Given this list of marker genes Gm10723, Gm22009, Gm37035, 4931440P22Rik, Gm34240, Shox2, Gm9701, 9330121J05Rik, Vmn2r-ps4 (NCBI Gene Id 100124547), Arhgef26, Rpl32-ps, Gm18588, Gm17952, Kpna4, Ppm1l, Ccnl1, Lxn, Vmn2r3 (vomeronasal 2, receptor 3), Vmn2r1, Gm8349, Gm412, Il12a, Vmn2r6, B3galnt1, Arl14, Nmd3, Gm8565, P2ry1, Gmps, Vmn2r-ps7, Gm25919, Plch1, Vmn2r-ps9, Vmn2r5, Mir16-2, Tiparp, Gm9700, Gm18717, Gm8515, Rap2b, Vmn2r-ps12, Vmn2r-ps11, Vmn2r-ps10 (vomeronasal 2, receptor, pseudogene 10), 4930535E02Rik, Gm22073, Kcnab1, Gm22165, Dhx36, A330015K06Rik, Gm18382, Lekr1, Gm25222, Ift80, Mlf1, Gm34379, Gm6546, Gm37359, Vmn2r7 (vomeronasal 2, receptor 7), Gm17212, A730090N16Rik, Gm5139, Vmn2r-ps6, Gm35299, Vmn2r-ps13, Gm19901 (predicted gene, 19901), Gm1647, Iqschfp, Gm8388, Vmn2r-ps3, Strit1, Gm18294, Mir15b, Veph1, Vmn2r128, Gm17213, Gm35584 (NCBI Gene Id 102639225), Gm26442, Tpi-rs2, Gm10292, Gm35106, Vmn2r2, Mir8120, Rarres1, Gm6555, Mfsd1, Smc4, Gm22279, Slc33a1, Gpr149, Iqcj, 1110032F04Rik, Gm5847, Vmn2r-ps8, Gm7270, Mme, Vmn2r4, Ssr3, Gm34780, Ptx3, Gm22433, E130311K13Rik, Gfm1, Rsrc1, Gm19024, Schip1, Gm17214, Trim59, Gm23897, Gm5540, here is a description of the gene set: Mouse Gene Set: chr3E1 studied in species Mus musculus